Given this list of marker genes CCND2, TFRC, PFKFB3, NDUFA4L2, MAFF, MT1F, TM2D2 (TM2 domain containing 2), PDK1, PFKP, VEGFA, ESRP1, FGF19, STC2, BNIP3, HK2, here is a description of the gene set: species: Mus musculus Human Gene Set: VANDESLUIS_COMMD1_TARGETS_GROUP_2_UP Genes up-regulated in 9.5 days post coitus (dpc) embryos with COMMD1 knockout compared to normal 8.5 dpc and 9.5 dpc embryos. from publication van de Sluis B, Muller P, Duran K, Chen A, Groot AJ, Klomp LW, Liu PP, Wijmenga C (PMID 17371845) COMMD1 (previously known as MURR1) belongs to a novel family of proteins termed the copper metabolism gene MURR1 domain (COMMD) family. The 10 COMMD family members are well conserved between vertebrates, but the functions of most of the COMMD proteins are unknown. We recently established that COMMD1 is associated with the hepatic copper overload disorder copper toxicosis in Bedlington terriers. Recent in vitro studies indicate that COMMD1 has multiple functions, including sodium transport and NF-kappaB signaling. To elucidate the function of Commd1 in vivo, we generated homozygous Commd1 null (Commd1(-/-)) mice. Commd1(-/-) embryos died in utero between 9.5 and 10.5 days postcoitum (dpc), their development was generally retarded, and placenta vascularization was absent. Microarray analysis identified transcriptional upregulation of hypoxia-inducible factor 1 (HIF-1) target genes in 9.5-dpc Commd1(-/-) embryos compared to normal embryos, a feature that was associated with increased Hif-1alpha stability. Consistent with these observations, COMMD1 physically associates with HIF-1alpha and inhibits HIF-1alpha stability and HIF-1 transactivation in vitro. Thus, this study identifies COMMD1 as a novel regulator of HIF-1 activity and shows that Commd1 deficiency in mice leads to embryonic lethality associated with dysregulated placenta vascularization.